Given this list of marker genes SLC19A1, MYT1 (NCBI Gene Id 4661), G3BP1, MVD, PRPF4, OARD1, MTA1, ATG5, SIT1, EPS15L1, GALR2, DYNC1I2, FH, GSDMD, INSM1, SLC10A1, B3GAT1, GCK, COMMD4 (NCBI Gene Id 54939), MRPS30, B4GALT1, EIF2B5, USP53, MYOT, CPNE6, RASGRF1, CEP55, SRSF6, PPIC, PLK4, NPAS2, IMPA1, JAG1 (jagged canonical Notch ligand 1), PRKRIP1, PTPRF, PDE12, CCND1, SCGB1D2, NDST4, CTRB2, PATZ1, GSN-AS1, BPNT2, SLC10A3, SLC19A4P, IL36G, GPM6A, COL1A2 (collagen type I alpha 2 chain), ZNF24, TUBAL3, RAB36, MDFI, GABRE (NCBI Gene Id 2564), GABRB1, PRDM10, PIR, EMC2, MGLL, MAPK8IP2, TMPRSS5, NSG2, BMP2 (bone morphogenetic protein 2), P2RX4, MMP26 (NCBI Gene Id 56547), ZBTB10, DBP, ENSG00000284948, MTRF1L, PRPSAP1, SLC9A5, RIN2, APPBP2 (NCBI Gene Id 10513), NIPSNAP2, ETV2, LRRC8B, CSF2, RNF185, CD28, KIF4A, DBF4B, ITPR1, GATD3, CLCN1, SEMA5A, DCTN6, CYP4B1, NTS, CDK13, GMCL1, CDH17, DNMT3A, PLA2G12A, MMP1, PMPCB, LAGE3, ZNF557, KLHL26, SIRPB1, RADX, TXNL4A, NUDT15, CHIT1, SLC39A4, PHLPP2, CD209, MSH3, TRMT13, DNAJC22, PRPSAP2, VHL, MED17, SIVA1, EIF2D, RNF7, MT1H, CASP7, WBP2, ZNF124, RBM38, CSE1L, ABR, PDE9A, RAB35 (NCBI Gene Id 11021), VWF, SLC25A3, PALLD, FERMT1, SCNN1B, MT1HL1, CRABP2, FRAS1, BUB1B (BUB1 mitotic checkpoint serine/threonine kinase B), ZNF354A, KRT38, ELP1, DDX31, UBE2NL, MBNL3, TRAF4, CASP10, NTHL1, BCR, KLHL29, HAND2-AS1, TXN2, OR1A2, ARTN, RACK1, NUDC, IL6, TSPAN1, INHBA, DEPDC1 (NCBI Gene Id 55635), CBX6, ZNF589, GEMIN4, KLHL28, GPR37, TRPA1, CLCA2, LOXL2, ACOX3, PREP, FKBP4, OSTM1, AMIGO2, UBE2I, TFR2, ADNP2, COL9A3, SETD4, GPC4, E2F8, SPO11, TBCB, FMO5, SFRP4 (NCBI Gene Id 6424), MRS2, TUT4 (terminal uridylyl transferase 4), RNF41, RPL21, SNRPN, POPDC2, PRKRA, NDRG3, NDUFA4L2, PDE10A, GPN2, ACE2, FAM98A, HNRNPDL, RAB3D, YTHDC2 (YTH N6-methyladenosine RNA binding protein C2), ITGB5, MRPS10, NHERF2 (NCBI Gene Id 9351), IKZF1, GDPD3, here is a description of the gene set: studied in species Homo sapiens NOD2 is an intracellular receptor for the bacterial cell wall component muramyl dipeptide (MDP) and variants of NOD2 are associated with chronic inflammatory diseases of barrier organs e.g. Crohn disease, asthma and atopic eczema. It is known that activation of NOD2 induces a variety of inflammatory and antibacterial factors. The exact transcriptomal signatures that define the cellular programs downstream of NOD2 activation and the influence of the Crohn-associated variant L1007fsinsC are yet to be defined. To describe the MDP-induced activation program, we analyzed the transcriptomal reactions of isogenic HEK293 cells expressing NOD2wt or NOD2L1007fsinsC to stimulation with MDP. Importantly, a clear loss-of-function could be observed in the cells carrying the Crohn-associated variant L1007fsinsC, while the NOD2wt cells showed differential regulation of growth factors, chemokines and several antagonists of NF-κB, e.g. TNFAIP3 (A20) and IER3. Human Gene Set: GSE22611_UNSTIM_VS_2H_MDP_STIM_NOD2_TRANSDUCED_HEK293T_CELL_DN Genes down-regulated in HEK293 cells over-expressing wildtype NOD2: untreated versus muramyl dipeptide for 2h. from publication Billmann-Born S, Till A, Arlt A, Lipinski S, Sina C, Latiano A, Annese V, Häsler R, Kerick M, Manke T, Seegert D, Hanidu A, Schäfer H, van Heel D, Li J, Schreiber S, Rosenstiel P (PMID 21335489)